The following is a description of a gene set: species: Homo sapiens Genes down-regulated in rectal but up-regulated in colon carcinoma compared to normal mucosa samples. To characterize patterns of global transcriptional deregulation in primary colon carcinomas, we did gene expression profiling of 73 tumors using oligonucleotide microarrays. For 30 of the tumors, expression profiles were compared with those from matched normal mucosa samples. We identified a set of genes with highly significant deregulation between tumors and mucosa samples (P < 1e-7). A significant proportion of these genes mapped to chromosome 20 (P = 0.01). Seventeen genes had a >5-fold average expression difference between normal colon mucosa and carcinomas, including up-regulation of MYC and of HMGA1, a putative oncogene. Furthermore, we identified genes that were significantly differentially expressed between lymph node-negative and lymph node-positive tumors (P < 0.001), the functional annotation of which revealed a preponderance of genes that play a role in cellular immune response and surveillance. The microarray-derived gene expression levels of 20 deregulated genes were validated using quantitative real-time reverse transcription-PCR in >40 tumor and normal mucosa samples with good concordance between the techniques. Finally, we established a relationship between specific genomic imbalances, which were mapped for 32 of the analyzed colon tumors by comparative genomic hybridization, and alterations of global transcriptional activity. Previously, we had conducted a similar analysis of primary rectal carcinomas. The systematic comparison of colon and rectal carcinomas revealed a significant overlap of genomic imbalances and transcriptional deregulation, including activation of the Wnt/beta-catenin signaling cascade, suggesting similar pathogenic pathways. from publication Grade M, Hörmann P, Becker S, Hummon AB, Wangsa D, Varma S, Simon R, Liersch T, Becker H, Difilippantonio MJ, Ghadimi BM, Ried T (PMID 17210682) Human Gene Set: GRADE_COLON_VS_RECTAL_CANCER_DN, and this is the list of marker genes: CPSF7, CDIN1, MPI, ANP32A, ESPL1, SLC31A1, THBS3, MAGEA5P, TAGLN2, KMT2E, KLK15, LMNB2, DCLK1, ADSS1, GRAMD1B, ANAPC5, RNASE4, FGF12, DUSP7, CRYZL1, H2AC18, VPS26B, RETREG3, ID3, KLRK1, WFDC2, C15orf39, BLOC1S6, FRAS1, RAD23A, PHLDA1, AP5Z1, EPB41L3, TCF3, POLL (NCBI Gene Id 27343), TRPM1, PCSK1N, BICD1, PIP4P1, PRICKLE4, QTRT1 (queuine tRNA-ribosyltransferase catalytic subunit 1), RPL17, FZD9, ALDH1L1, FLYWCH1, PIAS3, ANGEL1, PYY2, TNFRSF13B, PTHLH, PHLDB1, SLC30A1, ULK1, FCF1, MNT, ANKRD40